Given this list of marker genes HRAS, MAP2K2, ARAF, KRAS, RAF1, AREG, SOS2, BRAF, NRAS, GRB2, MAPK3, EGFR, MAP2K1, SOS1, MAPK1, here is a description of the gene set: AREG-EGFR-RAS-ERK signaling pathway. Pathway ID: N00279. Pathway type: Reference. Pathway class: nt06260 Colorectal cancer. Human Gene Set: KEGG_MEDICUS_REFERENCE_AREG_EGFR_RAS_ERK_SIGNALING_PATHWAY Pathway Definition from KEGG: AREG -> EGFR -> GRB2 -> SOS -> RAS -> RAF -> MEK -> ERK studied in species Homo sapiens